The following is a description of a gene set: species: Homo sapiens Genes down-regulated in peripheral blood mononuclear cell 7d or 14d vs 0d in adults (15-25) after exposure to Attenuvax, time point 7 or 14D, administered subcutaneous Human Gene Set: DHIMAN_PBMC_ATTENUVAX_AGE_15_25YO_SUBQ_7_OR_14DY_DN Cellular immunity to measles vaccination is not fully understood at the effector response and gene expression levels. We enrolled 15 healthy individuals (15-25 years old) previously vaccinated with two doses of measles-mumps-rubella-II vaccine to characterize their cellular immunity. We detected a spectrum of lymphoproliferative response (median stimulation indices of 3.4), low precursor frequencies of interferon-gamma (median 0.11%) and interleukin-4 (median 0.05%) by Elispot, and cosecretion of Th1 and Th2 cytokines after measles virus stimulation. Further, global gene expression was examined in five subjects from this cohort after vaccination with an additional dose of measles vaccine (Attenuax, Merck) to identify the genes involved in measles immunity. Linear mixed effect models were used to identify genes significantly up or downregulated in vivo between baseline and Days 7 and 14 after measles vaccination. Measles vaccination induced upregulation of a set of genes, which play a role in measles immunity, signal transduction, apoptosis, cell proliferation, and metabolic pathways. Among the genes that were downregulated, only interferon-alpha is known to have a direct role in measles immunity. This study suggests that measles vaccination leads to activation of multiple cellular mechanisms that can override the immunosuppressant effects of the measles virus and induce immunity. from publication Dhiman N, Ovsyannikova IG, Oberg AL, Grill DE, Jacobson RM, Poland GA (PMID 16571413), and this is the list of marker genes: ARHGAP11A, OPCML, MOXD1, ERBB3, DHPS, XPC, SCEL, RBM6, CBS, PDK3, RBP1, GCLM, NOTCH3, APPBP2, HGF, ABCB4, RIN2, RCVRN, IFNA1